The following is a description of a gene set: from publication Steger DJ, Lefterova MI, Ying L, Stonestrom AJ, Schupp M, Zhuo D, Vakoc AL, Kim JE, Chen J, Lazar MA, Blobel GA, Vakoc CR (PMID 18285465) The histone H3 lysine 79 methyltransferase DOT1L/KMT4 can promote an oncogenic pattern of gene expression through binding with several MLL fusion partners found in acute leukemia. However, the normal function of DOT1L in mammalian gene regulation is poorly understood. Here we report that DOT1L recruitment is ubiquitously coupled with active transcription in diverse mammalian cell types. DOT1L preferentially occupies the proximal transcribed region of active genes, correlating with enrichment of H3K79 di- and trimethylation. Furthermore, Dot1l mutant fibroblasts lacked H3K79 di- and trimethylation at all sites examined, indicating that DOT1L is the sole enzyme responsible for these marks. Importantly, we identified chromatin immunoprecipitation (ChIP) assay conditions necessary for reliable H3K79 methylation detection. ChIP-chip tiling arrays revealed that levels of all degrees of genic H3K79 methylation correlate with mRNA abundance and dynamically respond to changes in gene activity. Conversion of H3K79 monomethylation into di- and trimethylation correlated with the transition from low- to high-level gene transcription. We also observed enrichment of H3K79 monomethylation at intergenic regions occupied by DNA-binding transcriptional activators. Our findings highlight several similarities between the patterning of H3K4 methylation and that of H3K79 methylation in mammalian chromatin, suggesting a widespread mechanism for parallel or sequential recruitment of DOT1L and MLL to genes in their normal on state. species: Mus musculus Genes up-regulated during adipogenesis of 3T3-L1 cells (fibroblast). Human Gene Set: STEGER_ADIPOGENESIS_UP, and this is the list of marker genes: LIPE, FFAR2, PNPLA2, CP, FABP4, CEBPA, MMD, NR1H3, HP, STOM, CIDEA, PPARG, CD36, HSD11B1, ADIPOQ, RETN, GYG1, ENPP2, ACSL1, PCK1, CIDEC